Given this list of marker genes LGALS3, CHIT1, ADAM10, ASAH1, TCN1, AP2A2, DBNL, HP, ITGAX, ENPP4, SNAP23 (synaptosome associated protein 23), PTPRN2, CLEC4C, STOM, OLR1, OSCAR, GAA, TIMP2, LYZ, DOK3, ALDOA, TARM1, ARMC8, TMEM179B, TCIRG1, CYBB, SERPINB10, ANO6, CDA, VAMP1, ATP6V0A1, PLAU, RAB14, SIGLEC5, STXBP2, CEACAM1, CST3, DSP, DYNLL1, ILF2, PRCP, LAMTOR2, CD55, GOLGA7, SNAP25, CD93, OLFM4, LAMTOR3, HGSNAT (NCBI Gene Id 8119), KCNAB2, MGAM, SERPINB6, RAC1, TMC6, CANT1, LAMTOR1, COPB1, DSG1, RHOA, CD177, CLEC4D, ATAD3B, LRG1, STX7, NIT2, CD53, NRAS, GGH, SLC11A1, CHRNB4, ITGAM, DSC1, TSPAN14, PGM1, CYSTM1, PTX3, VPS35L, PPBP, STBD1, SVIP, YPEL5, HBB, SERPINB12 (serpin family B member 12), ATP6V0C, NFASC, PLD1, DYNC1LI1 (NCBI Gene Id 51143), ATP11A, CYFIP1, IDH1, CYBA, PTPRB, SLC2A3, RAP2C, FPR2, PGLYRP1, FCAR, DIAPH1, CTSS, SPTAN1, RAP2B, CLEC12A, FOLR3, NCKAP1L, QPCT, LAMP1, FRMPD3, ADAM8, LAMP2, FPR1, ADGRE3, CD58, CAMP, QSOX1, CR1, PKP1, ALDOC, ORM1, MMP9 (matrix metallopeptidase 9), TNFAIP6, VAMP8, CD59, PRG3, ITGB2, CNN2, PTPN6, CD47, LILRA3, TMT1A, ATP6AP2, UBR4, FLG2, SIRPA, CTSH, LILRB2, NBEAL2, LTF, PRSS3, CD300A, GPR84, MCEMP1, ARL8A, TMEM63A, CSTB, GSDMD, CXCL1, CD33, TBC1D10C, CTSD, STXBP3, LTA4H, PTAFR, MMP8, CEACAM8, SIGLEC14, CLEC5A, B2M, LAIR1, FTH1, TRPM2, ATP8B4, CFP, CRISP3, FCER1G, here is a description of the gene set: Human Gene Set: GOCC_TERTIARY_GRANULE A secretory granule that contains cathepsin and gelatinase and is readily exocytosed upon cell activation; found primarily in mature neutrophil cells. studied in species Homo sapiens